Given this list of marker genes TMEFF2, FOXO3, NFYB, SP1, ID2, COL1A2, DDIT3 (NCBI Gene Id 92982), MYC, DNTT, GADD45A, NDRG2, ZFP36L1, CEBPD, NFYA, TMEM126A (NCBI Gene Id 84233), ZBTB17, NDRG1, DNMT3A, CDKN1B, WNT5A, GTF2H2, S100A7, SMAD3, ERBB2, MAX, ALDH9A1, TSC2, CCND1, SFRP1, CDKN1A, HDAC1, CFLAR, EP300, HDAC3, MXD4, DKK1, RBL1, CLU, LGALS1, IRF8, FTH1, ITGB1, SPI1, SMAD4, SFXN3, CCL5, HMGCS2, BRCA1, SLC11A1, NFYC, ITGA6, TJP2, SMAD2, CREB1, CDKN2B, CSDE1 (NCBI Gene Id 7812), PDGFRB, BCL2, TBP, CEBPA, GFI1, PTPA, ITGB4, here is a description of the gene set: Human Gene Set: PID_MYC_REPRESS_PATHWAY from publication Schaefer CF, Anthony K, Krupa S, Buchoff J, Day M, Hannay T, Buetow KH (PMID 18832364) Validated targets of C-MYC transcriptional repression species: Homo sapiens